The following is a description of a gene set: Human Gene Set: SWEET_LUNG_CANCER_KRAS_UP species: Mus musculus Genes up-regulated in the Kras2LA mouse lung cancer model with mutated KRAS. from publication Sweet-Cordero A, Mukherjee S, Subramanian A, You H, Roix JJ, Ladd-Acosta C, Mesirov J, Golub TR, Jacks T (PMID 15608639) Using advanced gene targeting methods, generating mouse models of cancer that accurately reproduce the genetic alterations present in human tumors is now relatively straightforward. The challenge is to determine to what extent such models faithfully mimic human disease with respect to the underlying molecular mechanisms that accompany tumor progression. Here we describe a method for comparing mouse models of cancer with human tumors using gene-expression profiling. We applied this method to the analysis of a model of Kras2-mediated lung cancer and found a good relationship to human lung adenocarcinoma, thereby validating the model. Furthermore, we found that whereas a gene-expression signature of KRAS2 activation was not identifiable when analyzing human tumors with known KRAS2 mutation status alone, integrating mouse and human data uncovered a gene-expression signature of KRAS2 mutation in human lung cancer. We confirmed the importance of this signature by gene-expression analysis of short hairpin RNA-mediated inhibition of oncogenic Kras2. These experiments identified both a pattern of gene expression indicative of KRAS2 mutation and potential effectors of oncogenic KRAS2 activity in human cancer. This approach provides a strategy for using genomic analysis of animal models to probe human disease., and this is the list of marker genes: MARCHF5, HLA-DQA2, HPN, F7, ATP6V0A1, KRT18, RGCC, PLA2G5, PGLYRP1, CAPZA3, WFDC21P, CCT3, CYBA, TLE5, SLC4A4, ELF5, VMP1, RPL17, VEGFB, LITAF, NPDC1, PFDN2, BASP1, CAMSAP1, COTL1, GGCX, TMEM50B, TMEM268, APOC1, CHRNB1, ITGA4, RPL8, POLG, HSPA5, EIF1AX, PLXNB2, LRP2, MARCO, ENTPD1, IGHA2, CES3, IQGAP1, PCBD1, CD14, MEF2B, ERRFI1, GJB2, HSPA1B, LAMB3, CASK, HIBADH, COL18A1, FPR2 (NCBI Gene Id 2358), TGFBI, EIF2AK4, KNG1, PLP2, ARL8B, HDC (histidine decarboxylase), PCYT1A, BTG1, REEP6, B4GALNT1, H2AC8, LCP1, ME1, IGHV1-2, CDK2AP2, ESRP1, CCND1, SLC31A1, CH25H, IBSP, VASP, TGOLN2, AXL, TFCP2L1, RO60, LPCAT1, GARS1, AREG, IL4R, OSTF1, AXIN1, EHMT2, G6PD, MEG3, UOX, PPARG, LGALS3, BST1, MATN4, F10, MAPRE1, C1QB (complement C1q B chain), HOXD1, ST7, HK2, EEF2, TSPAN8, UBXN1, GRHPR, IGHV1-24, ACTN1, PTPRF, CYB5R1, HEXA, EIF4G1, FBP2, ACSL5 (acyl-CoA synthetase long chain family member 5), RABGGTB, MANF, FAM162A, APEX1, ROS1, TMEM62, ITGB2, MPEG1, TBC1D24, SERPINE2, INHBB, SLC16A1, RDH11, SHC1, PSAT1 (phosphoserine aminotransferase 1), CHCHD7, CIP2A, POLR1C, MT1X, SLC25A39, CTSK, ATXN10, NAGK, ATP6V1C1, RNF4, CLIP4, ADGRG1, IL11, KRT7, ZFP1, RFK, AASS, PRXL2A, RPS2, SPECC1, STXBP2, SHMT1, VAMP2, EPCAM, TACSTD2, HLA-DRA, FKBP2, ITIH4, H19, F3, TNFSF9, ACADL, ERH, CSRP2, KDELR1, CCR5, BMP4, BSG, WLS, GOLM1, PHLDA1, RNF149, CHI3L1, PLBD1, GCH1, GFUS, ATP1A1, THBS1, S100A1, NEK4, SERPINE1, HM13, TOM1L1 (target of myb1 like 1 membrane trafficking protein), TAOK3, PCYOX1, PKM, PHB2, NR2F1, EPHA7, RPL6, LRRFIP1, PTGS1, HAP1, ADSS1, CRB3, RPS8, RNF181, CHIA, ITGAX, HLA-DQB1, MAN1A1, ELL2, PIGA, UBQLN2, MBTD1, FNTA, PIP4K2C, SPP1, IL18, TGIF1, DUSP6, ATP6V0D1, EEF1D, XBP1, CEBPA, CD9, HIF1A (hypoxia inducible factor 1 subunit alpha), ELOVL1, KCNK1, LDHA, TRBC1, ID2, EDEM1, RIDA, GJB3, GNL3, CD74, ATP6V0C, S100G, RACK1, RPL10A, TOB1, PRB3, CHL1, GRINA, PSMB5, TM2D2 (TM2 domain containing 2), PON2, CCL15, MAPK1, CTSA, MMP12, SEC23B, ITPR2, GSTT1, BTG3, GAPDH, PAPOLA, LY75, NCL, RNASET2, CRLF1, GADD45A (NCBI Gene Id 1647), CLCN5, LPCAT3, CTSD, HMGB3, ANK3, SLPI, NAPSA, PRDX5, CLU, TES, STARD10, PLIN2, PSCA, PDIA6, KRAS, PRELID1, C1QC, HLA-DMB, RPL36, ACLY, NHSL3, TSR1, ANXA4, HMGN1, AK1, PSMD4 (proteasome 26S subunit ubiquitin receptor, non-ATPase 4), ORM1, GNE (glucosamine (UDP-N-acetyl)-2-epimerase/N-acetylmannosamine kinase), KRT8, KLF5, POLR2E, TNNT1, CTSZ, FAM3C, ALDOA, PIP5K1B, PPP1R14B, ZNF282, ADIPOR2, C16orf89, CKMT1B, PGK1 (phosphoglycerate kinase 1, NCBI Gene Id 5230), SPINT1, MLEC, OSBPL1A, EIF4B, SLC38A2, CD68, LAP3, SNX10, PARM1, IGKV2D-29, ATOX1, IFI30, PGLS, CNIH2, FAM117A, RAP1GAP, TANK, LBP, ETV2, TULP2, LAS1L, NME2, MTIF2, DSC2, FUCA1, LRG1, TPI1, PSMD5, MDFI, C5, TPM4, MSR1, PLA2G7, MIEN1, IGLV1-50, ATP5F1C, ALDOC, TYROBP, FMR1, CA8, CTSB, SLAIN1, HSPH1, PHLDA2, PSEN1, PAFAH1B3, RPL3, MYH7, ADAM19, CHD4, BBLN, KLHDC2, CYB5R3, FCGR2B, CSTB, HSPA9, IGFBP3, BRD7, SIVA1, ARG2 (arginase 2), SDC1, LY6D, SND1, CNDP2, SPG21, NABP1, PABPC1, B3GAT3, NPC2, SLC15A2, SCG3, PISD, BCL2A1, PFKL, SLC12A2, HHEX, ACE2, PLD3, GNS, BEX1, ZNF143, ACTN4, ST6GAL1, MYDGF, CCDC186, HDLBP, TMEM30A, VAMP8, MT1F, CKS2, IGHG1, KCNJ15, BHLHE40, MUC1, NUCB2, ZFTRAF1, CLDN3, HLA-DMA, CD44, HNF1B, PPP2R5C, NNT, SFTPB, AZIN1, RPL37, ATP11A, PLET1, SLC34A2, LAMC2, ZFP42 (ZFP42 zinc finger protein), ST13, CTSS, PSAP (NCBI Gene Id 83009), HSPA8, RPS18, ST3GAL4, PKHD1, ACSL4, CD63, SIRPA, LAPTM5, GJA3, C17orf49, GALNT3, CTSC, SOAT1, HLA-DRB1, EIF3E, CITED2, PRDX4, CDKN1A, PTGR1, ARG1, CYRIB, ITGA8, CCL23, COL15A1, TCEAL9, NDUFAF4, ITM2C, MRC1, DLK1, RNASE3, ZDHHC6, CSF2, MRPS34, CEACAM1, PSME1, DAP, MIA2, ZDHHC3, VIL1, CTSH, CLDN7, RRBP1, FASN, SCAMP1, BEX4, SOCS2, NMT1, CLIC1, NUP88 (nucleoporin 88), RPL28, CLDND1, ADCY7, SRSF6, RBP4, SCD, NFIL3, LCN2 (NCBI Gene Id 3934), GPI, PRNP, ENO1, TNFAIP1, PRCC, CSF2RB, CTNND2, GJA1, CRYGD, ARGLU1, PDK3, CPOX (NCBI Gene Id 201541), GLRX (NCBI Gene Id 90885), IL13RA2, SAT1, MRPS18B, MDFIC, AVPI1, NUDT4, TMEM30B, FKBP4, TLCD4